Given this list of marker genes Kdm5b (lysine demethylase 5B), Pcp4 (Purkinje cell protein 4), Syt7, Palm, Tagln3, Ulk1, Aff3, Dpf1, Gpc2, Rbfox3, Cask (NCBI Gene Id 236691), Elavl4, Ccng2, Nfasc, Dcc, Pik3r3, Nol4, Grina, Agap3, Olfm1, Wdr47 (WD repeat domain 47), Stxbp1, Adgrl1, Nnat, Abr, Dcx, Chn1, Dtx1 (deltex 1, E3 ubiquitin ligase), Ap3b2, Nav1, Chrnb2, Ppfia2, Elavl3, Mtcl3, Sox11, Crmp1, Pde10a, Myt1l, D430019H16Rik, Apc2, Dpysl5, Phf21b, Trp53inp2, Cirbp, Pak5, Tubb3, Disp2, Mmp24, here is a description of the gene set: Genes selectively expressed by cells committed to neuronal differentiation beginning in the subventricular zone, in most cases extending into the intermediate zone and cortical plate of embryonic day 14.5 mouse cortex. from publication Bedogni F, Hevner RF (PMID 34321999) species: Mus musculus Mouse Gene Set: HEVNER_SUBVENTRICULAR_ZONE_AND_UP_NEURON_FATE_COMMITTED_CELLS